Given this list of marker genes ARNT2, PROK2, PHYH, NSMF, DCC, SCN9A, MFN2, IL17RD, SEMA3E, OTX2, KISS1R, SOX2, HS6ST1, PROKR2, FLRT3, ATP13A2, TACR3, ANK1, FGF10, SEMA3A, ADCY3, FGF17, WDR11, NHLH2, DNAI1 (NCBI Gene Id 3393), FGF8, HESX1, SLC39A14, SMCHD1, FGFR2, CHD7, CCDC141, FEZF1, TCF12, SOX10, SOX3, DUSP6, PEX7, FGFR1, LZTFL1, SPRY4, ARSL, FGFR3, ANOS1, GNRH1, NDNF, TAC3, FSHB, KISS1, SHH, here is a description of the gene set: Anosmia Human Gene Set: HP_ANOSMIA An inability to perceive odors. This is a general term describing inability to smell arising in any part of the process of smelling from absorption of odorants into the nasal mucous overlying the olfactory epithelium, diffusion to the cilia, binding to olfactory receptor sites, generation of action potentials in olfactory neurons, and perception of a smell. species: Homo sapiens